The following is a description of a gene set: part of: Extracellular matrix organization Reactome Pathway: Fibronectin matrix formation studied in species Mus musculus electronically inferred by orthology from the curated human pathway This event has been computationally inferred from an event that has been demonstrated in another species.<p>The inference is based on the homology mapping from PANTHER. Briefly, reactions for which all involved PhysicalEntities (in input, output and catalyst) have a mapped orthologue/paralogue (for complexes at least 75% of components must have a mapping) are inferred to the other species., and this is the list of marker genes: Ceacam1, Itga5, Col5a3, Col7a1, Col4a2, Col4a5, Col4a6, Col2a1